Given this list of marker genes PKD1, SLC4A1, AP2S1, CREBBP, EDNRA, IGF2, SPRED1, ACVR1, GTF2IRD2, LIMK1, CDKN1A, CFTR, SLC5A1, NCF1, PAX2, CLDN2, CLDN19, CLDN16, KCNH1, CHKA, OPLAH, GSTM3, KRT17, PREPL, BAZ1B, SI, SLC36A2, DCTN4, SERPINH1, GCM2, DSE (dermatan sulfate epimerase), TBC1D7, PHEX, AGXT, BTNL2, CDKN2C, ELN, XDH, SLC37A4, CYP24A1, USP8 (ubiquitin specific peptidase 8), CLCN5, GANAB, PLCD1, HSPG2, MEN1, GTF2IRD1 (GTF2I repeat domain containing 1), CLDN10, MGME1, SLC6A14, ATP7B, CEACAM3, ARMC5, ADAMTSL1, CDKN1B, CDC73, G6PC1, COQ6 (NCBI Gene Id 51004), ARSK, SERPINA1, PPM1B, HFE, ROR2, GCLC, METTL27, STX1A, SLC3A1, OXGR1, BICC1, SLC22A12, MYL9, HOGA1, CTH, DNAJC30, SLC34A1, OCRL, EIF4H, EP300, AIP, MIF, DNAJB11, SLC26A9, ATP6V1B1, FBN1 (NCBI Gene Id 7470), CACNA1D, MOCS1, MOCS2, SLC1A1, RFC2, MPV17, FKBP6, CLCA4, GNA11, CHST14, SLC11A1 (solute carrier family 11 member 1), GTF2I, VDR, KL, KCNQ1OT1, PKD2, GRHPR, CAMKMT, BUD23, SLC26A1, SLC7A9, KDM1A, HGD, CDKN2B, AGPAT2, SLC34A3, HPRT1, ALG5, ALG9, ADCY10, SETBP1, CASR, TMEM270, DEPDC5, PLG, SLC34A2, APRT, SLC2A9, HMOX1, VPS37D, PIDD1, CDKN1C, SLC9A3, TBL2, TGFB1, IFT140, CLIP2, GNAS, ZFX, MOCOS, CEACAM6, NOD2, CTNS (NCBI Gene Id 1497), PRPS1, ANTXR1, NHERF1, BSCL2 (NCBI Gene Id 84753), CA2, HLA-DRB1, HNF1B, KCNQ1, KCNN4, here is a description of the gene set: Human Gene Set: HP_NEPHROLITHIASIS species: Homo sapiens The presence of calculi (stones) in the kidneys. Nephrolithiasis